Given this list of marker genes SLC35C1, TRIM46, IRAK1BP1, TUBB6 (tubulin beta 6 class V), TMEM120B (transmembrane protein 120B), LHFPL4, COX20, RNF26, TBC1D2B (TBC1 domain family member 2B), MAFF, SBK1, ZDHHC23, CHAC1, TPPP, RAB5B, SYNPO2, PLXNA3, IL17A, CAMKV, TMEM222, BRD2, SLC6A17, OAS2, LRRK2, VPS37D (NCBI Gene Id 171020), PPFIA4, FBXO27, PDPR, SUMO1 (small ubiquitin like modifier 1), BAP1, SRP68, PLCG1, DIAPH1, ATP2A2, CTIF, GALK2, NPC1L1, MAPK8IP1, SUPT16H, C19orf53, LAT2, LIF, ACSM5, POC1A, MARK4, LHPP, WBP1L, RGS6, GTPBP1, SLC35E2B, TOMM34, ZNF512B, SLC25A21, MTCL2, RRAGD, GRM7, FHIP2A (NCBI Gene Id 57700), USH1C, TSPAN7, PRKAG1, SAMD4B, VDR, RORA, FBRS, GLDN, FIBCD1, TMEM179, ATG7, MTSS2, CACNB1, UBAP1, DYNLL2, KCNQ2, SLC7A1, ARHGDIG, NAP1L2, B3GNT7, CYP26B1, PLEKHH3, GMPPB, WWP2, USP32, MAPK8IP3, MED26, AGO1, SHOC2, SCARF1, COPG2, WDTC1, ZBTB34, here is a description of the gene set: Human Gene Set: MIR3918 Genes predicted to be targets of miRBase v22 microRNA hsa-miR-3918 in miRDB v6.0 with MirTarget v4 prediction scores > 80 (high confidence targets). from publication Chen Y, Wang X (PMID 31504780) studied in species Homo sapiens